Given this list of marker genes AVIL, DGAT2, MOGAT1, PNPLA2, DGKH, PGS1, APOA2, GPAM, DGKA, DGKB, DAGLB, DGKI, DGKG, PLB1, MOGAT2, DGKD, DGKQ, DGKE, PLCE1, DGKZ (NCBI Gene Id 8525), DGKK, GPAT4, DGAT1, PLA2G15, LIPE, DAGLA, here is a description of the gene set: species: Homo sapiens Human Gene Set: GOBP_DIACYLGLYCEROL_METABOLIC_PROCESS The chemical reactions and pathways involving diacylglycerol, a glyceride in which any two of the R groups (positions not specified) are acyl groups while the remaining R group can be either H or an alkyl group.